The following is a description of a gene set: studied in species Homo sapiens The chemical reactions and pathways resulting in the formation of nucleotide-sugars, any nucleotide-carbohydrate in which the distal phosphoric residue of a nucleoside 5'-diphosphate is in glycosidic linkage with a monosaccharide or monosaccharide derivative. Human Gene Set: GOBP_NUCLEOTIDE_SUGAR_BIOSYNTHETIC_PROCESS, and this is the list of marker genes: GFPT1, GMDS (GDP-mannose 4,6-dehydratase), GNE, GFPT2, GNPNAT1, FPGT, PGM3, FUOM, GFUS, GNPDA2, FCSK, UAP1, HK1, UAP1L1, AMDHD2, UGP2, MPI, SLC35A1, SLC35C1, GMPPB, GMPPA (NCBI Gene Id 29926), CMAS, UXS1, GNPDA1, NAGK, UGDH, PMM1, PMM2, NANP, NANS